Given this list of marker genes IL1A, NXPH1, CLIP1, DLL1, JPH1, CITED2, FZD4, EIF4ENIF1, ZDHHC17, GCLC, JPH3, RAPH1 (Ras association (RalGDS/AF-6) and pleckstrin homology domains 1), KIAA1671, LCA5, ANKRD17, GATA2, PTCH1, NCOA7, SHOC2, PIAS1, OSBPL6, CYFIP2 (NCBI Gene Id 81032), ATP2A2, KIF18A, DLG2, HOXA1, HMGCR, SMAD9, GABRG2, CTDSPL2, CREB1, BTBD3, NDNF, PPP2R2C, SLC5A1, ANO4, SERP1, NAMPT, HSPA12A, KIF13A, PPP2R5D, RSL24D1, ATAD2B, USP16, ZNF143, PHF12, GP6, VSX2, L1CAM, ARHGAP12, HP1BP3, ZFAND5, PLEKHA5, RMC1, DOCK9, USP32, CALD1, KIAA0825, LRP12, NECAB1, C1S, PDZRN3, AXIN1, MTREX, USP7, EFNA3, ITGB1, TMEM128, PSMG4, IL15, ZNF638, TDO2, NR2C2, MBD5, PPP1CC (protein phosphatase 1 catalytic subunit gamma), BTG1, HECTD2, PREX1 (NCBI Gene Id 57580), GAS1, CENPA, PIK3C3, KDM2B, OSBPL8, MEF2A (myocyte enhancer factor 2A), WNT5A, VPS35L, TBK1, SRI, ZNF43, USP43, ANTXR1, RAB10, UNC5C, AK5, HORMAD1, ZNF560, HAPLN1, STXBP5L, SLC22A23, CSPP1, TCF7L2, EOMES, PHC3, GGACT, ERC2, CWC25, SH2B3, NCAPH, ZNF385B, ENSG00000277067, CLSTN1, CPNE3, NFKBIA, SALL1, RNF4, C5orf15, LDLRAD4, NPAS3, TNRC6B, TSC22D2, NCOA1, NDUFC2, MED13, DUSP16, MCM6, RASL11B, RALGPS1, LIMCH1, MT2A, ALX1, RABGAP1L, RAD21, THSD7A, MTSS1, EPHA7, TTC7B, SNX9, JUN, PGRMC2 (progesterone receptor membrane component 2), ESF1, PCGF2, GPR176, TMEM237, HMGCS1, SERPINB7 (serpin family B member 7), SSH2, PRKD3, HK2, FER, GOLM1, PDPK1, TP63, FBRSL1, MBNL3, SEC24D, ATAD5 (ATPase family AAA domain containing 5), REV3L, PPFIA1, FNIP1, SLC2A13, DCTN2 (NCBI Gene Id 1640), LMO3, UNC50, SNRPB2, TNFAIP8, TMEM170B, GRID2, NUDT16, CTNND2, SLC10A7, PRDM8, SLAIN2, TOX3, UCK2, SUN1, TRHDE, ARID4B, PUM2, NTN4, MED13L, CYTH3, HIPK1, LANCL2, MLLT10, NRXN3, SMG1, LARP4, NLK, PLCB1, WNK3, ANKRD61, ZNF236, PMP22, RAB27B, KCNK1, CDH13, PSD3, UBE2V2, ACKR4, BRD10, SP3, SIN3A, WDR33, FRMD4A, TMCO1, C11orf87, VAMP2, GABRA2, TRIP10, BBX, SPRY3, SBNO1, SOS2, CLIC2, NECTIN3, STON2, LRATD1, CDH11, PAIP1, LTBP3, FMNL2, ITPRIPL2, GTF2IRD1, KLHL36, ACTR1B, NECTIN4, DENND4A, DGKI, FBXL3, SYT4, CARM1, ASTN1, ADAM23, KRBOX1, ZIC2, RXRA (retinoid X receptor alpha), PDS5A, LINC03104, RSPO2, MCUR1, PURB, KCNJ13, PHF20L1, DAB2IP, PUM1, DIP2A, MYO9B, MFAP5, SORCS3 (sortilin related VPS10 domain containing receptor 3), AP4S1, SCAMP2 (NCBI Gene Id 10066), ANKRD12, RASAL2, RBBP5, BCOR, KIAA0408, DACH1, SAT1, LRRC8C, SF3B1, RAB3IP, ZMYM5, AHDC1 (AT-hook DNA binding motif containing 1), CLOCK, NDST1, M6PR, MBTD1, SRGAP1, ELAVL1 (ELAV like RNA binding protein 1), NUDT4, LDLR, KLHL24, ARID1B, ABTB2, VSTM2B, ZMIZ1, TMEFF1, MEMO1, HMGN1, KDM6A, VPS13D, BMPR1A, RAP1GAP2, LRIG1, STARD13 (StAR related lipid transfer domain containing 13), CENPJ, ATAD2, SEPTIN7, CRISP3, MAP3K20, SPX, AP3S1, RAB5C, KCNJ6, TAB3, RTN4IP1, DMGDH, CADM2, TIAL1, ZBTB38, SERTAD2, HIF1A, C1GALT1C1, PRDM12, PIK3R1, CKS2, LCE1E, ARHGAP44, GJB7, PANK3, UBE2G1, TCF4, NAB1, EPSTI1, FAR1, DENND5A, FAM228A, PARP8, SEC63, HOOK3, POLK, CPEB2, AKAP1, DENND4C, DIP2C, HS6ST3, CELF2, YIPF4, ZNF354C, RHOT1, MEF2C, CDH2, NAV2, SCRN1, BNC2, AFF3 (ALF transcription elongation factor 3), RPS6KA5, MYT1L, DSCAML1, NPR3 (natriuretic peptide receptor 3), USP21, PAG1, PTGER3, TMEM106B, ARHGEF38, GNPTAB, SCN1A, OTUD1, MAP3K1, ATP5F1A, ANK2, SNRNP48, FOXO1, ITGBL1, ADARB2, MBNL2, SLC38A2, TNFSF11, ENDOD1, DYRK4, KLF4, TIA1, TBC1D22B, COLEC12, TMCO3, SPARCL1, IRX3, ZNF718, SUSD6, HAT1, MYCBP2, COG3, GRM5, MAP3K2, ALCAM, WASF3, DCUN1D1, GABRG3, CXADR, GRHL2, ZNF91, BASP1, SP1, SVEP1, HS3ST3B1, ARHGAP5, RAPGEF2, DHX36, EEA1, COQ3, FUBP1, INSM2, GTF2H1 (NCBI Gene Id 2965), ADAM28, PAPSS2, AKR1D1, BCL7A, CAMK2N1, C1QL1, E2F3, FAXC, IQCK, GJC1, ARFGEF1 (NCBI Gene Id 25860), TGFBRAP1, LINC03105, MEGF11, GDF6, NEO1, NCL, FBXW11, F3, ACAP2 (ArfGAP with coiled-coil, ankyrin repeat and PH domains 2), NDST3, ZNF431, FAM217B, CXCL8 (NCBI Gene Id 3576), MGAT3, EGR2, ADCY1, CACNB4, GABRA5, BCL11A, IFRD1, STAM, BAZ1A, KALRN, CAPZA2, FOXJ3, ATP5MK, ZNF384, FAM169A, KRBOX5, MIER3, VASH2, CDC14A, AGTPBP1, HSF5, EYA1, BOD1L1, CALN1, ITPRID2, GDNF, SEC24B, CUL5, REEP1, PCGF5, FBXO33, SRPX, ZNF148, ZMYND8, SMAP1, GSKIP, KPNA4, SLC25A12, RGS10, HIVEP2, ALDH9A1, FAM114A1 (NCBI Gene Id 92689), LYRM7 (LYR motif containing 7), DEFB132, TMEM170A, here is a description of the gene set: Genes predicted to be targets of miRBase v22 microRNA hsa-miR-493-5p in miRDB v6.0 with MirTarget v4 prediction scores > 80 (high confidence targets). species: Homo sapiens from publication Chen Y, Wang X (PMID 31504780) Human Gene Set: MIR493_5P